Given this list of marker genes Daglb, Il1b (NCBI Gene Id 16176), Tardbp, Tgfbi, Lpl, Ankrd44, Stxbp6, Fau, Yipf4, Cytip, Csf1r, Plbd1, Nxpe4, Lrwd1, Fosb, Naca, Meaf6, Bola2, Ypel3, Mtdh, Celf4, Otulinl, Fos, Clec4n, Rnf13, Coro1a, Ccr2, Uba52, Egln1, Ifngr1, Ccl6, C1qbp, Lrrc20, Tmem176a, Eef2, S100a4, Rap1a, Rras, Ldlrad3, Arl5c, Klf4, Clec4a2, Tmem88, Cd14, Rnf130, Faap24, Hes1, Eif3h, Snapc5, Tmem176b, Cd300a, Arhgap9, Ankrd10, Ikbkb, Fth1, Rack1, Lrp1, Eef1a1, Npm1, Clec4a3, Ptpn12 (protein tyrosine phosphatase, non-receptor type 12), Abi3 (NCBI Gene Id 66610), Fcgr2b, Eif3f, Slc38a2, Gpx1, Gngt2, Clec4a1, Uck2, Cdc42ep3, Higd2a, Cyp4f16, Btg1, Imp3, Lclat1, St8sia4, Cd74, Itgav (NCBI Gene Id 76358), Eef1b2 (NCBI Gene Id 80613), Trps1, Ppp4r3a, Setx, Susd3, Cd300c2, E2f8, Fxyd5, Ctdsp2 (CTD small phosphatase 2), Treml4, Hpgd, Adgre4, Emp3, Cx3cr1 (NCBI Gene Id 13051), Klf2, Rgs2 (NCBI Gene Id 19735), Nhp2, Dusp1, Abca9, Cox7a2l, Limd2, Tpm1, H2ac24, here is a description of the gene set: Cytokines mediate cell-cell communication in the immune system and represent important therapeutic targets. A myriad of studies have highlighted their central role in immune function, yet we lack a global view of the cellular responses of each immune cell type to each cytokine. To address this gap, the authors created the Immune Dictionary, a compendium of single-cell transcriptomic profiles of more than 17 immune cell types in response to each of 86 cytokines (>1,400 cytokine-cell type combinations) in mouse lymph nodes in vivo. A cytokine-centric view of the dictionary revealed that most cytokines induce highly cell-type-specific responses. For example, the inflammatory cytokine interleukin-1β induces distinct gene programmes in almost every cell type. A cell-type-centric view of the dictionary identified more than 66 cytokine-driven cellular polarization states across immune cell types, including previously uncharacterized states such as an interleukin-18-induced polyfunctional natural killer cell state. Genes negatively differentially expressed in cell type: Monocyte upon treatment with cytokine: IFN-α1 in mouse lymph nodes in vivo. from publication Cui A, Huang T, Li S, Ma A, Pérez JL, Sander C, Keskin DB, Wu CJ, Fraenkel E, Hacohen N (PMID 38057668) species: Mus musculus Mouse Gene Set: CUI_MONOCYTE_IFNA1_RESPONSE_DN